The following is a description of a gene set: species: Mus musculus Mouse Gene Set: chr1C2, and this is the list of marker genes: Gm11581, 1700039I01Rik, Plekhm3, Gm38058, Gm44468, Mir6899, Sec61g-ps2, Gm11587, Cryge, Klf7, Wdr12, Gm11599, Pard3bos2, Gm13751, Fzd7 (NCBI Gene Id 14369), Cd28 (NCBI Gene Id 12487), Pard3b, Nop58, Ino80dos (INO80 complex subunit D, opposite strand), Crygc, Nrp2, Gm26457, 2810408I11Rik, Adam23, Gm8550 (NCBI Gene Id 675191), 4933402D24Rik, 9530026F06Rik, 2310016D23Rik, Crygb (crystallin, gamma B), Gm38388, Gm11605, Fam237a, Fam117b, Gm11578, Eef1b2, Snord70, Gm24942, Cmklr2, Gm13748 (NCBI Gene Id 102639767), Gm22281, Gm29152 (NCBI Gene Id 102640020), Cyp20a1, 4930587A21Rik, Mettl21a, Gm11609, Carf, Gm28980, Crygd, Mdh1b, Fastkd2, Abi2, Nbeal1, Ino80d, Rpl17-ps1, Gm28411, Gm26293, Pth2r, Gm7329, Rpl31-ps24, Gm11582, Rps27-ps1, 6030460B20Rik, Zdbf2, Gm13754, Pikfyve, Snora41, Gm13750, Gm24674, Ccnyl1, Gm4208, Gm29083, Dytn, Gm13749 (NCBI Gene Id 433315), Creb1, Gm11579, Pard3bos1, Sumo1, Cryga, Snord11, Fzd5, Raph1, Gm11591, Ica1l, Gm26287, Idh1, D630023F18Rik, Ctla4, Gm18829, Gm15464, Icos, Ndufs1, Eif4a-ps4, Gm29332, Gm38137, Rpl10a-ps1, Gm973, Gm11606, Bmpr2, Gm24788 (NCBI Gene Id 115487676), Rpl18-ps1, Akr1cl